Given this list of marker genes SH3BGRL3, SPI1, TSPAN4, OAS1, CYBB, LAMTOR2, APOC1, GLRX, HLA-DQB1, KCNMA1, SLC31A1, NCF1C, SLC31A2, PDIA6, HLA-DPA1 (NCBI Gene Id 7935), GLB1, CAPZA2, ATP6V1A, PRXL2A, MCEMP1, LAIR1, MS4A4A, LILRB5, COLGALT1, LRPAP1, HLA-DRB5, RENBP, LIMS1, FCHO2, RNF13 (NCBI Gene Id 11342), IDH1, CLTA, RNF130, STEAP3, LY86 (NCBI Gene Id 9450), FABP3, YBX1, FN1, ABCC3, UROD, LGALS3, NDUFS3, HLA-DQB2, MAFB, TMEM14C, RASSF4, APLP2, EMC3, CTSH, SERF2, POMP, SLC11A1, WARS1, RAB13, AVPI1, NDUFAB1, AXL, LIPA, ACOT7, FCGR2A, SNX2, CXCL16, GM2A, MARCKS, DDRGK1, HLA-DQA1, PHLDA3, RNASE1, RPS27L, ATOX1, RRAGD, RAB1A, FTH1, COL6A1, TOR3A, PTMS, DST, TRIP6, ATP5MC3, HLA-DRB1, CXCL9, NEK6, PSMA6, LAMP1, S100A6, ANXA2, RAC1, SMIM30, HSP90AA1, REEP5, VSIG4, CYP27A1, TMBIM1, HSP90AB1, PLA2G2D (NCBI Gene Id 26279), HLA-DRA, RETN, NAGK, ENG, MRC1, ACE, PCBD1, ACOT13, SLC40A1, DUSP23, SLC15A3, GPX4, LAP3, PGD, RALA, CD59, RILP, COX5B, HSD17B14, CYC1, ALDOA, DPP7, HLA-DQA2, FLNA, SH3BGRL, FABP5, IL13RA1, ALCAM, SIRPA, LILRB3, ATP6V0E1, FCGR2B, GLUL, PLPP3, ACTN1 (actinin alpha 1), TMSB10, PRDX4, TXN, HSD17B4, CSF1R, CIAO2A, ATG7, ENO1, CEBPA, CORO1B, CD81, PLEKHB2, S100A11, SDC2, BLOC1S1, PRCP, RGCC, SCCPDH, ATP6V1D, DYNLL1, COMT, AIF1, MCOLN1, ATP6V1F, NR1H3, CD86, PPT1, CISD2, MAN2B1, TNS1, C1orf162, TNFAIP2, IFI30, THEMIS2, VIM, GRN, TMED10, RBP4, TMBIM6, PAPSS1, ITGAM, GSN (gelsolin), MVP, HSPB1, RMDN3, LYZ, MMP9, P2RX4, BASP1, SERPINF1, MGST2, IL18 (NCBI Gene Id 3606), TFEC, TBC1D2, EPHX1, SMCO4, NPC2, NUPR1, SPG21 (NCBI Gene Id 51324), LAMP2, GGTA1, UNC93B1, CAVIN3, FDX1, CD63, NCF1, RAB7A, C5AR1, CALM2, SLC49A3, APOE, CYFIP1, PLEKHO1, ATP6V0B, COPRS, CTSL, ADA2, GAA, TM6SF1, HLA-DMA, GPCPD1, PTAFR (NCBI Gene Id 91527), MS4A6A, PRDX3 (NCBI Gene Id 29017), FPR3, SSR3, RHEB, FBP1, SDCBP, MRAS, MNDA, AKR1A1, RAB31, CHCHD6, GNS, TNFSF13B, ALAS1, FCER1G, CTSB, ELOB, RAB5C, SMS, TNFSF12, TMSB4X, SPP1, COL6A2, CHIT1, CHCHD10 (coiled-coil-helix-coiled-coil-helix domain containing 10), CTSK, SNX10, ATP6V0C, GSTO1, COX5A, C3AR1, C1QC, RNASE6, PDLIM7, ACP5, PSAP (prosaposin), ATP5PD, NDUFB9, ATP1B3, LGALS1, NAA20, CTNNA1, JPT1, RNH1, CYBA, RHOB, CAMP, PILRA, ARHGAP18, HMOX1, RAB11FIP1, VOPP1, FILIP1L, TGFBI, SCPEP1, ZNF385A, AKR1B1, FCGR1A, TSC22D1, DNPH1, CAMK1D (NCBI Gene Id 57118), MGST3, CLEC10A, CTSZ, CD84, PTPMT1, NANS, ATP5F1B (ATP synthase F1 subunit beta), PEA15, CTSS, C2, PSMA3, UBE2E2, OSBPL1A, BLVRB, HNMT, IFI27, TREM2, NCK1, TUBB6, TUBA1B (NCBI Gene Id 88851), TPP1, TFRC, PALLD, MX1, HAVCR2, SERPINA1, TMEM176A, SLAMF8, MARCO, UQCRC1, HLA-A, STAT1 (signal transducer and activator of transcription 1), ITM2B, LILRB4, YWHAH, C1QB, TREM1, MGST1, EIF4EBP1, ADAMDEC1 (ADAM like decysin 1), CD151, IFI6, SLC16A3, ABHD2, MSR1, SFTPC, ASAH1, PFKP, CLIC2, CD58, FTL, PDK4, TUBA1C, LGALS3BP, VAMP8, LY96, OLR1, SHTN1, SLC7A7, PTTG1IP, ECHS1, HLA-DMB, CD4 (CD4 molecule), GNB4 (NCBI Gene Id 59345), CBR1, HADHB, MFSD12, LGALS2, GUSB, SCD, PSMB3, PKM, SQOR, CAPG, CLEC7A (C-type lectin domain containing 7A), TMEM70, RHOA, ALDH1A1, A2M, LGMN, CIR1, PSME2, PCK2, PLSCR1, SPARC, FUCA1, HSPA1A, CD74, CLEC4E, CD300LF, LHFPL2, ALDH2, PMP22, QPCT, PPARG, ISCU, TXNDC17, CRIP1, EMP1, SDHB (succinate dehydrogenase complex iron sulfur subunit B), NEAT1, NCF2, GLIPR2, SLC1A3, RARRES1, GK, EMC7, CYB5A, PLD3, MICOS13, CREG1, C1orf54, IFNGR1, BHLHE41, SCARB2, TMED9, SGMS2, GABARAP, RAB32, PRDX1, MDH1, ANXA5, PSMD8, RAB20, SERPING1, PDXK, TYROBP, PTGDS, ZFAND5, HEBP1, VPS29, GNAI2, FCGRT, LGALS9, GCHFR, CD9, LRP1, ATP6V0D1, PDLIM1, LRRFIP1, G0S2, TMEM176B, ACAA2, NDUFA12, SLC25A5, FERMT3 (NCBI Gene Id 83706), CD14, VAMP5, MYL6, RDX, TXNRD1, ME1, CCL18, PLBD1, KCTD12, ITGB2 (NCBI Gene Id 3689), HEXB, TWF2, RNF149, PSMB6, ACO1, FUOM, IGSF6, GBP1, LTA4H, LACTB, GSTP1, MACROH2A1 (macroH2A.1 histone), HLA-DPB1, CHI3L1, MS4A7, TAGLN2 (transgelin 2), PYCARD, TCEAL4, TALDO1, KLF4, CTSA, DNASE2, CA2, C1QA, ARHGEF10L, VAT1, ATP6AP2, S100A13, GNAS, TCN2, SDSL, S100A10, ANPEP, IL3RA, MGLL, PLA2G7, CTSD, TMEM147, NOP10, LYSET (NCBI Gene Id 26175), ATP6AP1, HM13, TYMP, SLAMF7, ALOX5, SLC38A6, GPX1 (glutathione peroxidase 1), PSMB1, DNASE2B, NTAN1, ITGAX, ERP44, MMP14, HSD3B7, HSPE1, CPM, SOAT1, CTSC, ATF3, PLXDC2, AP2S1, FEZ2, HCK (NCBI Gene Id 3055), SLCO2B1, TSPO, UBD (NCBI Gene Id 95374), CSTB, GPX3, PARVB, ATP6V1B2, CPVL, NDUFB2, PSMB5, VDAC1, VKORC1, RRAS, SLC3A2, MFSD1, MTX1, CD40, PEPD, CD44, CST3, PPIC, MYOF, ABHD12, NDUFS8, GPNMB, CALU (calumenin), SQSTM1, SLC29A1 (solute carrier family 29 member 1 (Augustine blood group)), MRTO4, TIMM8B, GMPR, CORO1C, DHRS4, NME1, TIMP2, FMNL2, OSCAR, HSD11B1, CANX, ACP2, NCEH1, NPL, ISOC2, TMEM51, MGAT1, HEXA, CD68, TMEM205, C15orf48, MTCH2, RTN4 (NCBI Gene Id 57142), IL4I1, DAB2, GRB2, DPYSL2, HLA-DOA, PLAUR, HLA-DRB6, CALR, GRINA, AGPAT2, DBI (NCBI Gene Id 1622), BRI3, RBM47, ANXA4, CFD, PSMA7, GLA, SYNGR2, BCAT1, ARPC1B, MYDGF, KYNU, EPSTI1, APOC1P1, CXCL10, SGK1, BCAP31, HYAL2, here is a description of the gene set: studied in species Homo sapiens Human Gene Set: TRAVAGLINI_LUNG_TREM2_DENDRITIC_CELL from publication Travaglini KJ, Nabhan AN, Penland L, Sinha R, Gillich A, Sit RV, Chang S, Conley SD, Mori Y, Seita J, Berry GJ, Shrager JB, Metzger RJ, Kuo CS, Neff N, Weissman IL, Quake SR, Krasnow MA (PMID 33208946)